Given this list of marker genes MAPK14, RREB1, INS, FNDC5, PIM1, PTGS2, SOX13, TFE3, ZBTB7B, HNRNPU, NAPEPLD, VSTM2A, METRNL, BMP7, SIX1, FFAR4 (NCBI Gene Id 353126), here is a description of the gene set: species: Homo sapiens Any process that increases the rate, frequency, or extent of brown fat cell differentiation. Brown fat cell differentiation is the process in which a relatively unspecialized cell acquires specialized features of a brown adipocyte, an animal connective tissue cell involved in adaptive thermogenesis. Brown adipocytes contain multiple small droplets of triglycerides and a high number of mitochondria. Human Gene Set: GOBP_POSITIVE_REGULATION_OF_BROWN_FAT_CELL_DIFFERENTIATION